Given this list of marker genes CLCNKB, KCNJ5, CACNA1D, SCNN1B, SCNN1G, SCNN1A, SLC12A3, CYP11B1, CLCN2, CYP11B2, here is a description of the gene set: Primary hyperaldosteronism Human Gene Set: HP_PRIMARY_HYPERALDOSTERONISM studied in species Homo sapiens A form of hyperaldosteronism caused by a defect within the adrenal gland.